The following is a description of a gene set: studied in species Mus musculus Mouse Gene Set: GOBP_ANTIGEN_PROCESSING_AND_PRESENTATION_OF_PEPTIDE_ANTIGEN The process in which an antigen-presenting cell expresses peptide antigen in association with an MHC protein complex on its cell surface, including proteolysis and transport steps for the peptide antigen both prior to and following assembly with the MHC protein complex. The peptide antigen is typically, but not always, processed from an endogenous or exogenous protein., and this is the list of marker genes: Pdia3, Fcgr3, H2-T15, Clec4a3, H2-M2, Ide (insulin degrading enzyme), Fcer1g, H2-Ob, Marchf1, Trem2, Fcgr1, H2-M10.5, 2410137M14Rik, H2-DMb2, H2-DMb1, Lgmn, H2-D1, H2-Q4, Ctss, H2-M10.3, H2-M5, Unc93b1, H2-Eb1, Fcgr2b, Azgp1, B2m, H2-M10.4, H2-Q7, Tap2, H2-M10.1, H60b (NCBI Gene Id 667281), Raet1d, Traf6, H2-Ea, H2-Q10, H2-T24, H2-K1, Ulbp1, H2-M10.6, H2-T23, Pikfyve, H2-M3, H2-T3, H60c, H2-Q6, H2-Q2, H2-Aa, Slc11a1, Bag6, H2-T22 (NCBI Gene Id 15051), Ctsl, H2-T13, H2-Oa, Cd74, Marchf8, H2-M11, Mpeg1, H2-M1 (NCBI Gene Id 333725), H2-Eb2, Ctse, Clec4a2, Ifi30, H2-Ab1, Tapbpl, Calr, Tap1, Mr1, H2-T5, Tapbp, Clec4a4, Pycard, H2-M9, H2-Q1, H2-M10.2, Raet1e, Hfe, H2-DMa, Mfsd6